The following is a description of a gene set: Any process that stops, prevents, or reduces the frequency, rate or extent of muscle development. Mouse Gene Set: GOBP_NEGATIVE_REGULATION_OF_MUSCLE_ORGAN_DEVELOPMENT species: Mus musculus, and this is the list of marker genes: Sox15, Usp2, Fgf3, Nras, Sfmbt1, Lef1, Il6 (NCBI Gene Id 16193), Twist1, Ybx3, Hdac5, Sirt2, Tgfb1, Bmp4, Hdac7, Usp19, Luc7l, Bdnf, Fgf8, Hdac9